The following is a description of a gene set: An automatic response to a stimulus beginning with a nerve impulse from a receptor and ending with the action of an effector such as a gland or a muscle. Signaling never reaches a level of consciousness. Mouse Gene Set: GOBP_REFLEX species: Mus musculus, and this is the list of marker genes: Zpld1, Drd3, Cacna1a, Tmc1, Nmbr, Auts2, Slc1a1, Kcnma1, Pcdh15, Nmb, Npsr1, Usp46, Satb1, Aldh1a3, Nr4a3, Ascl1, Adra1a, Scn11a, Glra1, Hpn, Gja1, Afg3l2, Npnt, Tmc2, Pmp22, Cdh23, Cacng2, Glrb, Shank1, Foxp2, Slitrk6